Given this list of marker genes Agfg1, Cox17, Tent5d, Nkd1, Serpinf2, Lrp2, Eif4enif1, Slc46a3, Sp9, Irs1, Synm, Osbpl6, Lrrtm3, Cntn1, Zcchc14, Snap25, Neo1, Fabp5, Otud1, Tmem100, Tenm2, Lhfpl7, E2f4, Guf1, Tfpi, Rc3h1, Cyp1a2, Vmp1, Xk, Tssk4, Egf, Armc8, Utp14b, Dach1, here is a description of the gene set: species: Mus musculus Mouse Gene Set: MIR_1298_5P from publication Chen Y, Wang X (PMID 31504780) Genes predicted to be targets of miRBase v22 microRNA mmu_miR_1298_5p in miRDB v6.0 with MirTarget v4 prediction scores > 80 (high confidence targets).